The following is a description of a gene set: Human Gene Set: SHIN_B_CELL_LYMPHOMA_CLUSTER_7 species: Mus musculus Aside from Myc-activating translocations characteristic of plasmacytomas (PCT), little is known about genetic factors and signaling pathways responsible for the development of spontaneous B-cell lineage lymphomas of mice. Here, we characterized the transcriptional profiles of PCT, centroblastic diffuse large B-cell lymphomas (CBL), and high-grade splenic marginal zone B-cell lymphoma (MZL++) using high-throughput quantitative reverse transcription-PCR. Expression profiles of CBL and MZL++ were strikingly similar and quite unlike that of PCT. Among the genes expressed at significantly higher levels by PCT were a number involved in NOTCH signaling, a finding supported by gene set enrichment analyses of microarray data. To investigate the importance of this pathway, NOTCH signaling was blocked in PCT cell lines by treatment with a gamma-secretase inhibitor (GSI) or transduction of a dominant-negative mutant of MAML1. These treatments resulted in reduced expression of NOTCH transcriptional targets in association with impaired proliferation and increased apoptosis. GSI treatment of transformed plasma cells in a primary PCT also induced apoptosis. These results integrate NOTCH activation with oncogenic signaling pathways downstream of translocated Myc in the pathogenesis of mouse PCT, two signaling pathways also implicated in development of human multiple myeloma and T-cell lymphoblastic lymphoma. from publication Shin DM, Shaffer DJ, Wang H, Roopenian DC, Morse HC 3rd (PMID 19010892) Cluster 7 of genes distinguishing among different B lymphocyte neoplasms., and this is the list of marker genes: DVL1, ZFP36, DKK4, CDKN1C, APC, WNT4, IGF1R, NOTCH4, RB1, STAT6, TERT, DVL3, PTEN, IL6ST, BAD, NOTCH3, DICER1, GLI2, TRAF4, XRCC3, RARG, PTCH1, GSK3B, TEP1, PML, MAX, BCL6